Given this list of marker genes Abca16, Spmip3, Ube2f, Gm6313, Rad51ap2, Gm24296, Gm15039, Fam76a, Fhip2b, Ikbkg, Scn3a, Ninj2, Lag3, Ccr4, Kmt5c, Dync1h1, Hkdc1, Nme4, Mrpl22, Adck2, Milr1, Amigo1, Serpine2, Mir376c, Dnajb2, Tdrd9, Defb23, Ptp4a1, Gm20443, Safb2, Matk, Syngap1, Arf4, G6pc3, Mir3085, Gltpd2, Gm24068, Calcoco2, Rnpep, Gm12333, Mir3618, Fgfr1, Lratd1, Faiml, Top3a, Rbm28, Evl, Mto1, Mir337, Hlcs, Rsf1, Tldc2, 1810053B23Rik, Rogdi, Kdm1a, Rev3l, Tekt5, Zp1, Thap6, Recql5, Stradb, Gm17806, Tsg101, Rab43, Pds5a, Mpi, Ankdd1a, Gm4535, Chd7, Baz1b, Wdr75, 1700036A12Rik, Palld, Celf1, Dlgap5, Pdcd6ip, 1700025G04Rik, Pigh, Ralbp1, Vdr, Btnl1, Ushbp1, Gm25973 (NCBI Gene Id 115488840), 4933408N05Rik, Tcp1, Cdr2l, Pi4ka, Synrg, Nbeal2, Amz1, Wars1, Gon4l, Gm8398, Gm22935, Pbrm1, Cyp4a28-ps, Mdfic2 (MyoD family inhibitor domain containing 2), Ckap2, Gm24878, Rbck1, Myo5b, Cfap53, Bcas1, Tfrc, Jak1, Nsun4, Jakmip1, Dsc1, Efna3, Rcor3, Taar9, Esr1, Ift81, Gm23706, Oaz2-ps, Pigb, Itpr2, Recql, Ppp1cb, Rbm26, Mmp19, Gm7069, Ccdc14, Lancl1, Trpm1, Cep164, 1110028F18Rik, Capza1, 1700022A21Rik, Hecw2, Flad1 (NCBI Gene Id 319945), St3gal6, Spink10, Lrrc75aos1, Ino80d, Cfap74, Msh5, Ptges3, Ube2h, Gm16166, Nr6a1os, Arhgap28, Hhip, Rdm1, Pigc, Sp1, Dnajc13, Redic1, Pde4d, Gm5424, Klf8, Arpc5l, Myo15a, Gm12886, Babam1, Srp72, Setdb2, Eva1c, Or6c8, Gm8849, Dgcr8 (DGCR8, microprocessor complex subunit), Pdpr, Entpd1, Prim2, Hspa9, Tango2, Gm12936, Tap2, Gm23382, Habp2, Kcnab2, Mir7057, Sema4d, Gm37885, Islr, Nckap1, Uba52, H2-M5, Gm22881, Ubxn1, Olig3, Gm10848, Gm14491, P2rx7, Jkamp, G3bp2, Pask, Lims1, Gm8213, Pate2, Gpr45, Myo18a, Sf3a3, Gm5248, Gm10309, Mrpl36, Gm15032, Atp8b4, Gm15610, Reps1, Cfap69 (cilia and flagella associated protein 69), Pfkfb4, Ndfip2, Gm7097, Acad11, Btbd19, Ufsp2, Ttf1, Mir770, Shbg, Iho1, Mir1306, Gpr35, Gigyf2, Tmem252, Wdfy3, Rfx2, Arhgap45, Gm12654, Crppa, Vps39, Gm12608, 1700003F12Rik, Ly6g, Gm11665, Hdac4, Phlpp2, Mir7046, Zfp229, Tcf4, Galnt1, Gm10531, Il4, here is a description of the gene set: from publication Yevshin I, Sharipov R, Kolmykov S, Kondrakhin Y, Kolpakov F (PMID 30445619) Mouse Gene Set: ZFP457_TARGET_GENES species: Mus musculus